The following is a description of a gene set: Human Gene Set: HP_CARCINOID_TUMOR A tumor formed from the endocrine (argentaffin) cells of the mucosal lining of a variety of organs including the stomach and intestine. These cells are from neuroectodermal origin. studied in species Homo sapiens Carcinoid tumor, and this is the list of marker genes: MEN1, APC, IFNG, TSC2, TSC1, CDKN2C, ATRX (ATRX chromatin remodeler), LMNA, CDKN2B, SDHD (succinate dehydrogenase complex subunit D), CDKN1B, CDKN1A